Given this list of marker genes ARPC5, CLDN24, CLDN1, CLDN19, ACTR3, CLDN17 (claudin 17), CLDN5, ACTB (actin beta), CLDN10, ARPC2, CLDN14 (claudin 14), CLDN4, CLDN8, CLDN3, CLDN18 (claudin 18), CTTN, ACTR2 (actin related protein 2), CLDN6, CLDN7, ARPC1B, CLDN16, ACTG1, CLDN2, CLDN20, CLDN23, CLDN15, ARPC4, OCLN, CLDN34, ARPC5L, ARPC3, CLDN9, CLDN22, ARPC1A, TJP1, CLDN11, CLDN25, here is a description of the gene set: Human Gene Set: KEGG_MEDICUS_REFERENCE_TIGHT_JUNCTION_ACTIN_SIGNALING_PATHWAY Tight junction-Actin signaling pathway. Pathway ID: N01287. Pathway type: Reference. Pathway class: nt06135 Cytoskeletal regulation (viruses and bacteria). studied in species Homo sapiens Pathway Definition from KEGG: (OCLN,CLDN) == TJP1 == CTTN == ARP2/3 == (ACTB,ACTG1)